The following is a description of a gene set: species: Homo sapiens Catalysis of the reaction: a secondary alcohol + NADP+ = a ketone + H+ + NADPH. Human Gene Set: GOMF_CARBONYL_REDUCTASE_NADPH_ACTIVITY, and this is the list of marker genes: KCNAB1, DHRS4L2, DHRS4, CBR1, DCXR, DHRS2, DHRS4L1, DHRS1, DHRS7, CBR3